Given this list of marker genes PFKL, EDN1, HMOX1, CA9, IGFBP1, TGFA, VEGFA, DDIT3, EDN2, AK3, TFF3, PKM, FOS, LRP8, P4HA1, L1CAM, PLAUR, CD99, ENO1, LDHA, CXCL8 (NCBI Gene Id 3576), PFKP, CA12, TGFB1, PTGS2, XRCC6, TH, BHLHE40, PDGFB, FGF3, TAGLN, HIF1A, APEX1, EPO, SLC2A3, ENPEP, TXN, RP1, CDKN1B, IGF2 (insulin like growth factor 2), STC1, TGM2, NFKB1, FTL, HGF, HK1, SAT1, TF, F3, EPAS1, GAPDH, ANGPT2 (NCBI Gene Id 285), HDAC9, COL5A1, SLC2A1, BNIP3, XRCC5, MIF, CDKN1A, CP, PGK1, VIM, MMP13, SPP1, BIK, IL6, ADM, JUN, PGF, BNIP3L, FLT1, ALDOA, CCL2, PRPS1, IGFBP3, TGFB3, TEK, HK2, CCNG2, IGFBP2, TFRC, here is a description of the gene set: studied in species Homo sapiens Human Gene Set: HARRIS_HYPOXIA Cells undergo a variety of biological responses when placed in hypoxic conditions, including activation of signalling pathways that regulate proliferation, angiogenesis and death. Cancer cells have adapted these pathways, allowing tumours to survive and even grow under hypoxic conditions, and tumour hypoxia is associated with poor prognosis and resistance to radiation therapy. Many elements of the hypoxia-response pathway are therefore good candidates for therapeutic targeting. Genes known to be induced by hypoxia from publication Harris AL (PMID 11902584)